The following is a description of a gene set: from publication Castro I, Dee MJ, Malek TR (PMID 23018461) studied in species Homo sapiens Human Gene Set: GSE39110_UNTREATED_VS_IL2_TREATED_CD8_TCELL_DAY6_POST_IMMUNIZATION_DN Genes down-regulated in CD8 T cells 6 days after immunization: control versus IL2 treatment. Much is known concerning the cellular and molecular basis for CD8+ T memory immune responses. Nevertheless, conditions that selectively support memory generation have remained elusive. Here we show that an immunization regimen that delivers TCR signals through a defined antigenic peptide, inflammatory signals through LPS, and growth and differentiation signals through the IL-2R initially favors antigen-specific CD8+ T cells to rapidly and substantially develop into tissue-residing T effector-memory cells by TCR transgenic OVA-specific OT-I CD8+ T cells. Amplified CD8+ T memory development depends upon a critical frequency of antigen-specific T cells and direct responsiveness to IL-2. A homologous prime-boost immunization protocol with transiently enhanced IL-2R signaling in normal mice led to persistent polyclonal antigen-specific CD8+ T cells that supported protective immunity to Listeria monocytogenes. These results identify a general approach for amplified T memory development that may be useful to optimize vaccines aimed at generating robust cell-mediated immunity. Gene expression analysis was performed for OT-I T cells on day 3 and day 5 after activation with ovalbumin and LPS in vivo with and without treatment with IL-2 using an agonists IL-2/anti-IL-2 complexes (IL2/Jes-6.1), and this is the list of marker genes: IFNGR2, MSRB2, CHD3, YEATS4, PEAR1, TMLHE, FAM81A, TFCP2, SP6, EXT1, ST6GAL1, CTSS, MTSS1, LDLR, DHCR7, FAM210A, SMPDL3A, PPM1B, CDK5R1, ATP6V1D, ZMAT1, UBE2D2, TRIM56, WNT10A, C6orf118, PDK1 (pyruvate dehydrogenase kinase 1), GRHL1, SPRED2, TTC3, BCL6, PRICKLE1, CYTH3, CCDC126, APP, FCRL1, GPM6B, IFT25, LRIG1, SCML4, PPP1R3C, TMEM158, ART3, SLC16A5, ADK, RPA1, CCDC28A, TNFRSF9, TRIM35, NATD1, DGKD, TBC1D2B, DCAF11, TWSG1, MYB, OAZ2, TUBA1A, KDM6B, TRIB2, TPD52 (NCBI Gene Id 7163), ANKRD6, EOMES (NCBI Gene Id 8320), PFN2, LIPA (lipase A, lysosomal acid type), MMD, KCNC2, FAM3C, LUC7L2, NUCB2, TGFBR3, KIF13A, GCNT1, CYTIP, RFLNB, F2RL1, EGR2, TIAM1, ETS1, ZNF24, HLA-DOB, BCO1, TREH, GABRR2, CABCOCO1 (NCBI Gene Id 219621), ZNF878, SSBP3, NIPAL1, FAM43A, ZNF281, STIM2, LDLRAD4, USP6NL, SHANK3, POU2AF1, GLTP, PLCB4, BAG3, ZNF608, PPIC, PLAGL1 (PLAG1 like zinc finger 1), CCDC28B, RASGRP1, TOX, IZUMO1R, LRRC42, ZC3H12D, LDHB, ARHGAP31, LPCAT1, STAT1, SEMA7A, SLC43A1, GLIS3 (GLIS family zinc finger 3), ZNF518B, DUSP10, CD200, ACTN1, PANK1 (NCBI Gene Id 53354), TSPAN3, LCLAT1, RETREG1, TPBG, CD81, PPTC7, EID2, ST8SIA6, EGR3, TSPAN32, WDFY2, MRPS6, DLG3, FAM8A1, SYNPO, EPB41L5, SLC22A25, AKAP12, NAV2, SYNJ2, CCDC141, MAP4K4, SNN, RNASET2, HIF1A, LRRC23, CIC, PACSIN1, BCL9, SALL2, PECAM1, CNPY4, RNF32, SQLE, HACD3, IL6ST, PLCL1 (phospholipase C like 1 (inactive)), ZNF217, IFT81, EPHX1, COTL1, KIF5C, NFIX, AFF3, DDR1, IGF1R, CEBPA, MAP7, CERS6 (ceramide synthase 6), GPRASP1, CYLD, TIMP2, ARHGAP5, ATP1B1, TESC, HMGN3, SLAMF6, MFHAS1, TSPAN13, UBXN8, DAPL1, EGLN3, MATK, WFS1, CD83, AGFG1, VCF1, TCF7, P2RX7, CEMIP2, TNFSF11, TOX2 (NCBI Gene Id 84969), PHACTR2, SPOCK2, DPY19L3, ATP6AP2, SHLD1, CXCR4, SMCO4, CASS4, ADH1C, CXCR5, C1orf74